The following is a description of a gene set: studied in species Mus musculus Mouse Gene Set: GOMF_INSULIN_RECEPTOR_SUBSTRATE_BINDING Binding to an insulin receptor substrate (IRS) protein, an adaptor protein that bind to the transphosphorylated insulin and insulin-like growth factor receptors, are themselves phosphorylated and in turn recruit SH2 domain-containing signaling molecules to form a productive signaling complex., and this is the list of marker genes: Igf1r, Insr, Prkcd, Grb2, Ptpn11, Jak2, Zfp592, Lonp1, Pik3r1, Insrr, Wdr6, Pik3ca, Pik3cb, Ncl